The following is a description of a gene set: Any process that results in a change in state or activity of a cell (in terms of movement, secretion, enzyme production, gene expression, etc.) as a result of a nutrient stimulus. Human Gene Set: GOBP_CELLULAR_RESPONSE_TO_NUTRIENT studied in species Homo sapiens, and this is the list of marker genes: MLXIPL, MED1, POSTN, LPL, TRIM24, LEP, COL1A1, CDKN2B, CASR, FOLR1, MTOR, MDM2, RXRB, XBP1, SRF, MAT2A, GPRIN3, MN1, PLD1, OGT, RXRA, KAT2B, MIR125B1, NCOA1, SAMTOR, CSNK1A1, RPS6KB1, SFRP1, SNW1, NFE2L2, BGLAP, USF2, VDR, SNAI2, PRMT1, TNC, FOLR2, CYP24A1, FGF23, GAS6, PENK, KANK2, PDK2, NCOA3, PIM1, PHEX, CYP27B1, FES, USF1, GDAP1